The following is a description of a gene set: species: Homo sapiens Genes changed in HBE cells (bronchial epithelium) after treatment with IL22 and IL17A. from publication Aujla SJ, Chan YR, Zheng M, Fei M, Askew DJ, Pociask DA, Reinhart TA, McAllister F, Edeal J, Gaus K, Husain S, Kreindler JL, Dubin PJ, Pilewski JM, Myerburg MM, Mason CA, Iwakura Y, Kolls JK (PMID 18264110) Emerging evidence supports the concept that T helper type 17 (T(H)17) cells, in addition to mediating autoimmunity, have key roles in mucosal immunity against extracellular pathogens. Interleukin-22 (IL-22) and IL-17A are both effector cytokines produced by the T(H)17 lineage, and both were crucial for maintaining local control of the Gram-negative pulmonary pathogen, Klebsiella pneumoniae. Although both cytokines regulated CXC chemokines and granulocyte colony-stimulating factor production in the lung, only IL-22 increased lung epithelial cell proliferation and increased transepithelial resistance to injury. These data support the concept that the T(H)17 cell lineage and its effector molecules have evolved to effect host defense against extracellular pathogens at mucosal sites. Human Gene Set: AUJLA_IL22_AND_IL17A_SIGNALING, and this is the list of marker genes: S100A7, CXCL9, CXCL1 (C-X-C motif chemokine ligand 1), CCL3, S100A12, DUOX2, IL19, DEFB4A, CSF3, IL36G, CXCL5